Given this list of marker genes COL5A1, MACROH2A1, DKK1, MAP2K1, MESP1, COL5A2, SOX17, here is a description of the gene set: Any process that modulates the frequency, rate or extent of endodermal cell differentiation. studied in species Homo sapiens Human Gene Set: GOBP_REGULATION_OF_ENDODERMAL_CELL_DIFFERENTIATION